Given this list of marker genes TIGAR, TP53, ACTN3, MIR210, CAVIN3, here is a description of the gene set: Any process that modulates the frequency, rate or extent of fermentation, the anaerobic enzymatic conversion of organic compounds, especially carbohydrates, to other compounds, especially to ethyl alcohol, resulting in energy in the form of adenosine triphosphate (ATP). studied in species Homo sapiens Human Gene Set: GOBP_REGULATION_OF_FERMENTATION